The following is a description of a gene set: Mouse Gene Set: chr2E3 species: Mus musculus, and this is the list of marker genes: Gm14015, Fshb, Gm13932, Or4k37, Or4f4-ps1, Gm13915, Or4f17-ps1, Emc7, Or4k52, Or4k47, Or4f53, Gm13923, Gm21985, Or4k51, Gm13902, Them7, Gm13929, Or4f60, Lpcat4, Or4f6, Gm13904, Or4k38, Or4f52, Ano3, Emc4, Paupar, Or4f54, Or4f14, Gm13914, Or4k45, Or4f4b, Gm13916, Pax6, Gm13937, Bdnf, Mettl15, Gm13924, Gm23749, Gm13928, Muc15, Or4f56, Or4g7, BB218582, Or4k44, Or4f14d, Or4f15, Olfr1304-ps1, Or4k50-ps1, Or4f62, Rpl35a-ps4, Or4k40, Or4k36, Or4k42, Chrm5, Platr8, Olfr1319-ps1, Or4f59, Or4f14b, Bbox1, Nop10, Rcn1, Or4f61, Elp4, Or4k48, Pax6os1, Or4k43-ps1 (olfactory receptor family 4 subfamily K member 43, pseudogene 1), Katnbl1, Or4g16, Ccdc34os, Mpped2, Gm13912, Lin7c, 4930527A07Rik, Or4k39, Nutm1, Rpl10-ps1, Kif18a, Lgr4, Kcna4, Gm22813, Slc5a12, Gm22676, Or4f47, Aven, Or4f14c, Or4k77, Or4k41, Slc12a6, Gm13961, Dnajc24, Or4f57, Or4k46-ps1, Or4f7d-ps1, Gm26421, Gm13935, Gm13930, Immp1l (IMP1 inner mitochondrial membrane peptidase-like (S. cerevisiae)), Fibin, Hadhb-ps, Arl14ep, Gm13922, Or4k49, Gm13954, Or4g17, Or4f7, Or4k35, Potefam1, Gm13992, Or4f58, Ccdc34, Dcdc5